Given this list of marker genes NLRP3, PPARA, COX6A1, SMARCD3, CHD9, PTK6, NCOA1, CREBBP, TGS1, NFE2L2, COX7A1, FABP1 (NCBI Gene Id 2168), COX5B, BLVRB, COX8C (cytochrome c oxidase subunit 8C), ABCC1, HBA1, COX6B1, STAP2, SIN3A, COX4I2, TBL1X, CYCS, NCOA2, HDAC3, STAT3, HMOX1, COX4I1, NCOA6, COX6A2, TXNIP, ALB, MT-CO3, COX8A, HELZ2, MT-CO1, COX6C, COX7A2L, CARM1, HBB, COX6B2, COX7A2, HM13, NCOR2, TBL1XR1, MT-CO2, SIN3B (SIN3 transcription regulator family member B), HMOX2, COX7B, NCOR1, COXFA4, BLVRA, COX7C, HIGD1C, COX5A, RXRA, MED1, BACH1, MAFK, here is a description of the gene set: studied in species Homo sapiens part of: Cellular response to chemical stress Reactome Pathway: Cytoprotection by HMOX1 Expression of heme oxygenase 1 (HMOX1) is regulated by various indicators of cell stress, while HMOX2 is expressed constitutively. Both catalyze the breakdown of heme into biliverdin (BV), carbon monoxide (CO), and ferrous iron. Biliverdin is immediately reduced to bilirubin (BIL). Both bilirubin and carbon monoxide can localize to different compartments and outside the cell. Cytoprotection by HMOX1 is exerted directly by HMOX1 and by the antioxidant metabolites produced through the degradation of heme. Additionally, due to the reactive nature of labile heme, its degradation is intrinsically protective.<br><br>HMOX1 confers cytoprotection against cell death in various models of lung and vascular injury by inhibiting apoptosis, inflammation, and immune cell proliferation. It binds to the NACHT domain of NLRP3 inflammasome, blocking its activation. In mouse it directly binds STAT3 to control the generation of pathogenic Th17 cells during neutrophilic airway inflammation. It also blocks phosphorylation of STAT3 by PTK6 and co-inhibits Socs3, a negative feedback factor of Stat3 activation, as well as RORγt, thereby decreasing Th2 and Th17 immune responses, and alleviating airway inflammation.<br><br>The beneficial effects of the three products generated by HMOX1 differ not only in their inherent molecular mechanisms, but also in their downstream cellular targets. To date, this is the only enzymatic system known to exhibit such characteristics. Iron is a vital component of many biological systems and is capable of producing hydroxyl radicals via fenton chemistry. For this reason, iron is sequestered by the storage multimer ferritin and to prevent oxidative damage while maintaining the iron pool. On the other hand, the protective effects of bilirubin and CO are broadly recognized, which has led to their consideration as therapeutics for a range of diseases. Bilirubin has been recognized as one of the most potent antioxidants in nature, and moderate increases of its serum level have been shown in numerous large-scale population and epidemiological studies to have a protective effect against cardiovascular and metabolic disease. These effects are mediated by bilirubin scavenging of superoxide anions and reactive nitrogen species (RNS), and by activating the transcription factor PPAR-alpha.<br><br>CO and biliverdin/bilirubin, have been shown to exert protective effects in the liver against a number of stimuli, as in chronic hepatitis C and in transplanted liver grafts. CO possesses intriguing signaling properties affecting numerous critical cellular functions including but not limited to inflammation, cellular proliferation, and apoptotic cell death. Binding of CO with key ferrous hemoproteins serves as a posttranslational modification that regulates important processes as diverse as aerobic metabolism, oxidative stress, and mitochondrial bioenergetics. The most important of these is the mitochondrial cytochrome c oxidase (Cco). By locally blocking mitochondrial respiration the main source of reactive oxygen species (ROS) in the cell is switched off. Additionally CO enables efficient reduction of methemoglobin (MetHb) by H2O2, thus preventing the generation of free heme in hemorrhagic diseases and malaria (Origassa and Câmara, 2013; Morse et al, 2009; Ryter et al, 2006; Cooper and Brown, 2008; Hinds and Stec, 2008).